The following is a description of a gene set: Mouse Gene Set: ZFP970_TARGET_GENES studied in species Mus musculus from publication Yevshin I, Sharipov R, Kolmykov S, Kondrakhin Y, Kolpakov F (PMID 30445619), and this is the list of marker genes: Ttc17, Cyp51, Acsl1, Gm11350, Runx2, Hspbp1, Runx2os1, Mpst (mercaptopyruvate sulfurtransferase), Gm11434, Tst, Dlx6, Terf1